Given this list of marker genes WDR1, PSTPIP1, PTPN6, NFKB1, GFI1, ELANE, OTULIN, CLPB (ClpB family mitochondrial disaggregase), TCIRG1, MEFV, SRP19, here is a description of the gene set: species: Homo sapiens Pyoderma gangrenosum Human Gene Set: HP_PYODERMA_GANGRENOSUM A deep skin ulcer with a well defined border, which is usually violet or blue. The ulcer edge is often undermined (worn and damaged) and the surrounding skin is erythematous and indurated. The ulcer often starts as a small papule or collection of papules, which break down to form small ulcers with a so called cat's paw appearance. These coalesce and the central area then undergoes necrosis to form a single ulcer.